The following is a description of a gene set: studied in species Homo sapiens CD4(+)Foxp3(+) regulatory T (Treg) cells originate primarily from thymic differentiation, but conversion of mature T lymphocytes to Foxp3 positivity can be elicited by several means, including in vitro activation in the presence of TGF-beta. Retinoic acid (RA) increases TGF-beta-induced expression of Foxp3, through unknown molecular mechanisms. We showed here that, rather than enhancing TGF-beta signaling directly in naive CD4(+) T cells, RA negatively regulated an accompanying population of CD4(+) T cells with a CD44(hi) memory and effector phenotype. These memory cells actively inhibited the TGF-beta-induced conversion of naive CD4(+) T cells through the synthesis of a set of cytokines (IL-4, IL-21, IFN-gamma) whose expression was coordinately curtailed by RA. This indirect effect was evident in vivo and required the expression of the RA receptor alpha. Thus, cytokine-producing CD44(hi) cells actively restrain TGF-beta-mediated Foxp3 expression in naive T cells, and this balance can be shifted or fine-tuned by RA. Genes up-regulated in comparison of conventional T cells treated with retinoic acid (tretinoin) versus untreated conventional T cells. Human Gene Set: GSE13306_RA_VS_UNTREATED_TCONV_UP from publication Hill JA, Hall JA, Sun CM, Cai Q, Ghyselinck N, Chambon P, Belkaid Y, Mathis D, Benoist C (PMID 19006694), and this is the list of marker genes: ISG20L2 (interferon stimulated exonuclease gene 20 like 2), DDX49, ABCF3, COMT, SOX7, POLE, DDRGK1, ELOVL6, MRPS18B, POU2F3, LRRC45, SLC4A9, PARP2, LMBR1, WDR5, HSD17B11, ALMS1 (ALMS1 centrosome and basal body associated protein), LTA4H, ZBTB8A, CUL4A, EML5, COL4A6, NF2, FFAR2, TOP3B, ADCK5, ZKSCAN5, FUBP3, ASAP1, ENSG00000267882, GRM2, IMPA1, RPS5, SYF2, NBDY, YTHDF1, NOL9, GPAT3, POP7, AQP12A, PI4KA, ALB, BTBD2, TERT, SHLD2 (NCBI Gene Id 54537), UGT2B15, THBS3, VTA1, ENTREP3, PARP11, CLASP1, IL27RA, ELN, FAM151B, BAAT, MFSD8, COQ6, TBC1D8B, SSUH2, MTHFSD, INO80E, CHRM4, FKBP10, TANC2, C1QTNF9, SHISA5, BCL9, S100A1, BRD9, CDK5, DCTPP1 (dCTP pyrophosphatase 1), MIDEAS (NCBI Gene Id 91748), SECISBP2, CYTH3, DNAAF5, TOPORS, SAV1, PCNX1, TTYH2, SLC16A11, DZIP3, PRKAR2B, MED4, ZSWIM7, CYC1, SLC9A3, HDAC3, G6PC2, CERS5, LSG1, CCL1, CHKA, COL13A1, TBL1X, PHLDA1, MVB12B, CCN3, RANBP2, CSF1, RNF135, IGFBP6, SP3, PDE2A, MRM1, DNAJC11 (NCBI Gene Id 55735), COX7B2, PIGS, NENF, CD82, TUBG2, FGFR4, NIBAN3, ASTL, CUEDC2, ZNF239, PCDHB1, IGHMBP2, PES1, MPP2 (NCBI Gene Id 4355), SCN4A, GM2A, STK40, IRF7, ZNF512 (NCBI Gene Id 84450), TNFSF14, BMF, APBB3, TEFM, MLLT1, PPP1R12B (NCBI Gene Id 4660), CDK14, HRC, TAGLN, GPR83, PTPN14, SDSL, PXMP4, EPHB6, P3H3, PIGP, SLC44A3, LETMD1, NCOA5, MRPL14, CHD6, SLC10A7, PRR15, OTUD5, DPAGT1, SPO11, SH3GL3, XXYLT1, C1orf198, RBM42, MAN2B1, VSTM2L, ST6GALNAC2, OPRL1, MTX3, TRADD, ACBD6, PRF1, RALGPS1, CCDC82, MS4A13, NPHP3, MTA1, GRB7, NDUFA4L2, FOXP4 (forkhead box P4), KCNK5, ZNF250, PLEKHA7 (pleckstrin homology domain containing A7), SLC25A28, TMEM50B, ARF4, SORCS3, COLGALT1, CYP26B1 (NCBI Gene Id 56603), SUV39H2, C16orf90, SMC4, NR1D1, ACKR2, ARHGAP8, EEFSEC, MFHAS1, FBXW4 (NCBI Gene Id 6468), CABP7, CD79B, PUS1, SHISAL1, GPATCH1, MTSS2, PLA2G1B, ATP8A1, LAMP1, PAQR9, TICAM1, UQCC1